Given this list of marker genes SLC7A5, ABCA8, ABCC11, SLC22A6, SLC18A1, SVOP, ABCC1, SLC47A2, MIR326, ATRAID, TMEM30A, ABCC5, SLC28A3, SLC22A18 (solute carrier family 22 member 18), SLC43A3, MIR133B, ABCB1, OSCP1, MIR873, MIR1-1, ABCG1, SLC28A2, MIR9-1 (microRNA 9-1), SLC31A1, ATP7B, MIR133A1, ABCB5, SLC22A5, MIR495, ABCC10, SLC37A3, MIR34B, SLC22A3, MIR508, SLC2A1, ABCC2, SLC15A2, ABCB11, ABCA3, SLC29A2 (NCBI Gene Id 3177), SLC17A3 (NCBI Gene Id 10786), ATP8B1, MIR185, SLC22A8, GJA1, SLC47A1, SLC29A4, ABCC4, RALBP1, SLC22A2, MIR451A, NR1I2, MIR186, SLC22A4, SLC19A1, ABCC3, SLC22A1, CLDN1, SLC29A1, MIR129-1, ABCG2, PDZK1, here is a description of the gene set: The directed movement of a xenobiotic into, out of or within a cell, or between cells, by means of some agent such as a transporter or pore. A xenobiotic is a compound foreign to the organism exposed to it. It may be synthesized by another organism (like ampicilin) or it can be a synthetic chemical. Human Gene Set: GOBP_XENOBIOTIC_TRANSPORT species: Homo sapiens